Given this list of marker genes PPP1R15B, DNAJB5, GORASP2 (NCBI Gene Id 26003), PACRG, COMP, OPTN, HSPE1, ATF6B, QRICH1, HSPB2, PTPN2, PRKN, CCND1, HSPA6, DERL2 (derlin 2), HERPUD1, AGR2, AKT3, ATF3, CREB3L4, DDIT3, ERP27, AKIRIN2, DNAJB1, ASB11, UFL1, OS9, NCK1, UBE2J2, HSPH1, SERP2, BAK1, DNAJC10, PTPN1, TMED2, XBP1, DAXX, HSPA8, HERPUD2, KLHL15, BBC3, HSPA1A, CREB3L3, CREB3L1, STUB1, AKT2, STC2, DNAJC4, TMBIM4, RNF126, PARP8, SDF2L1, EIF2AK2, JKAMP, UBR5, BCL2L11, FBXO6, UBE2W, CTH, CUL3, THBS4, MIR199A1, CHAC1, HSPB1, DERL1 (derlin 1), HSPA4L, DNAJB4, DAB2IP, FUT1, SERP1, VAPB, HSPB3, ERN2, ATF4, NCK2 (NCBI Gene Id 8440), EDEM1, AKT1, HSPA1L, TMTC4, ATAD3A, TRAM1, RNF7, PARP6, TOR1B, DDRGK1, ABCA7, HSPB7, ERMP1, DNAJC18, ATF6, MBTPS2, CDK5RAP3, MBTPS1, PIK3R1, CREBZF, ATXN3, HSPD1, HSPA5, STT3B, BFAR, PPP1R15A, PIGBOS1, DNAJB9, ERP44, UMOD, EIF2S1 (eukaryotic translation initiation factor 2 subunit alpha), HDAC6, CREB3L2, HSP90AB1, HSP90AA1, RPAP2, UBXN4, ERLEC1, COPS5, MANF, AMFR, RHBDD1, EDEM3, HSPB8, BAX, EIF2AK3, DERL3, BAG3 (BAG cochaperone 3), NFE2L2 (NCBI Gene Id 4780), F12, TBL2, DNAJB12, MFN2, TMEM33, KBTBD6, ELP6, WFS1, HSPA2, THBS1, RACK1, VCP, ERO1A, TMEM129, DNAJB14, PARP16 (poly(ADP-ribose) polymerase family member 16), CREB3, SERPINH1, UBR4, FICD, DNAJC3, FAF2, HSF1, BHLHA15, YOD1, DNAJB2, RHBDD2, ABCB10, TMBIM6 (NCBI Gene Id 7009), HSPA4, ERN1, EDEM2, CLU, TM7SF3, SELENOS, DNAJA1, CREBRF, BOK, CAV1, UFD1, EPG5, here is a description of the gene set: studied in species Homo sapiens Any process that results in a change in state or activity of a cell or an organism (in terms of movement, secretion, enzyme production, gene expression, etc.) as a result of a protein that is not folded in its correct three-dimensional structure. Human Gene Set: GOBP_RESPONSE_TO_TOPOLOGICALLY_INCORRECT_PROTEIN